The following is a description of a gene set: studied in species Homo sapiens Cell Cycle, Mitotic Human Gene Set: REACTOME_CELL_CYCLE_MITOTIC, and this is the list of marker genes: CEP192, H4C15, ORC4, CENPU, CENPL, H2AC8 (NCBI Gene Id 3012), TUBGCP4, ADRM1, PSMD8, POLD3, MCPH1, AAAS, CENPI, GORASP2, ORC2, TUBB2A, YWHAE, H3C1, CLASP1, H3C11, DNA2, NINL, CEP70, PSMB4, CDC7, MCM10, H2BC5, FIRRM, RFC5, CCNH (cyclin H), PTTG1, CENPF, NCAPH, CEP41, ABL1, CCNE2, LIN9, RBX1, FBXL7, PPP2CA, USO1, PSMA5, E2F6, RANGAP1, CDKN2A, CDT1, PPME1 (NCBI Gene Id 51400), BLZF1, FBXL18, GINS2, XPO1 (exportin 1), CNEP1R1, HDAC1, RPA4, CDC25A, NCAPG, POLD2, TUBGCP6, FBXW11, TUBA1A, CEP131, DYNC1LI1, NUMA1, PSMA1, PPP2R5B, PRKCA, LEMD3, TUBA1B, TOP2A, MIS18BP1 (MIS18 binding protein 1), H4C13, ZWILCH, LIN37, TUBA3C, NUP85, DCTN2, RRM2, OFD1, UBA52, H4C1, PLK4, UBE2I, CENPC, H4C5, GINS3, NME7, NUP43, FOXM1, H2BC6, RAE1, BTRC, CDKN2C, H3C10, NUP107, AKT1, E2F5, TFDP2, CEP290, H2BC15, UBC, ESPL1, ESCO2, MCM8, PKMYT1, ANAPC5, ANAPC7, CEP250, MZT2A, H2AC18, VPS4A, TUBG1, PDS5A, B9D2, MASTL, SKP1, CHMP6, BUB1B, CDK7, H4C14, H3C8, CDK11B, RAB8A, RCC1, H2BC3, SMC3 (NCBI Gene Id 9126), GTSE1, H3-3A (NCBI Gene Id 3020), SEC13, TUBA8, ERCC6L, PSMB3, CENPN, NSL1, MAPK3, SPAST, DBF4, PSMD6, ESCO1, H2BC7, MAD1L1, CCND2, HAUS1, KIF23, HSP90AA1, PSMC5, PPP2R1B, CEP135, HDAC8, CLIP1, CENPS, RFC2, CKAP5, MZT2B, RAD21, PSMB2, RBL1, FKBPL, H2BC11, PSMC6, PPP2R5C, NUP205, LYN, PMF1 (polyamine modulated factor 1), CEP152, POLA2, BIRC5, ZW10, GORASP1, PPP1CB, SKP2, CEP72, H2BC9, SMC1A, DSN1, SMC2, RCC2, FBXO5, SPC25, ENSA, LIN54, CENPP, BUB3, RPA1, CDC16, CENPM, CCND3, CSNK2B, CDC20, NUP37, KPNB1, LIG1, NDEL1, HJURP, OBI1, CABLES1, AKT3, PRIM1, RB1, RAN, H2AC7, H2AB1, PSMC1, CCNE1, SKA1, H2BC13, STAG1, CKS1B, NUP214, NDC80, CHMP3, GMNN, CHMP2B, LEMD2, NEK7, RPS27, NCAPH2, TUBB8B (tubulin beta 8B), H2AC20, CDC25B, KIF2A, UBE2S, TUBA4B, PSMD7, CSNK1E, NUP50, SUMO1, ANAPC1, MYBL2, AURKA, PPP2CB, ANAPC11, PTK6, CETN2, NEK2, H3C13, NUP58, DYNLL2, CDC14A (cell division cycle 14A), CDK2, PPP2R1A, TNPO1, TFDP1, AKT2, WEE1, CDKN1C, POLE3, PRKCB, CLASP2, RBBP4, NEK6, TUBB4B, PSMB7, CDKN1A, NUP133, PSMD14, TUBA3D, PPP2R2D, H2AC14, NEK9, PCNA, MCM3, MCM7, PRIM2 (DNA primase subunit 2), PPP2R5D, GINS4, RBL2, CEP63, PSMD1, POLD4, VRK1, STAG2, TUBGCP5, INCENP (inner centromere protein), MCM6, TUBB3, FEN1, HAUS4, SMC4, H2BC12L, TUBAL3 (tubulin alpha like 3), AJUBA, CDC25C, ARPP19, NIPBL, PPP2R5A, CDCA5, MCM5, CHMP4B, H2AJ, POLE4, E2F4, CENPJ, UBE2C, TPR, E2F3 (NCBI Gene Id 1871), CDC23, PPP1CC, ZWINT, SSNA1, MAX, H4C16, PPP1R12A (NCBI Gene Id 4659), TUBB2B, KIF20A, CNTRL, PPP1R12B, TK1, H3C6, MCM2, PSMA7, UBE2E1, NUP155, CENPQ, EMD, H2BC1, NEDD1, LMNA, CDC45, HAUS7, MIS12, E2F2, TUBA3E, RAB2A, UBE2D1, UBB, NUP54, H3C2, NUF2, OPTN, LPIN3 (NCBI Gene Id 64900), EP300, CDC27, TUBB1, ORC5, H2AX, H3C3, PRKAR2B, SET, PHF8, CC2D1B, NDC1, SGO1 (shugoshin 1), PCNT, CCNB2, BUB1, LBR, SGO2, H2BC17, PLK1, PHLDA1, H2AC4, TYMS (thymidylate synthetase), SPC24, TUBA1C, RPA2, RAB1B, PPP2R5E, FZR1, NUP62, ITGB3BP, PSMC4, PDS5B, PSMB6, TUBGCP3, H4C2, SEM1, SFI1, TUBG2, RAB1A, CHMP4C, NUP93, GOLGA2, PSMB5, ORC1, CENPT, SPDL1 (NCBI Gene Id 54908), CSNK2A2, AHCTF1, DYNLL1, HAUS2, H2BC12, HSP90AB1, H2AC19, HMMR, E2F1, SRC, PSMD2 (proteasome 26S subunit ubiquitin receptor, non-ATPase 2), PSMA3, H3-4, POLD1, NUP42, CDK4, VRK2, H2BC4, YWHAG, H4C8, MCM4, CDCA8, BORA, DYNC1I1, CCND1, H3C4, H2AZ2, KIF2C, MAPRE1 (microtubule associated protein RP/EB family member 1), TUBA4A, NUP188, NUP160, PSMD3, ANKLE2, SKA2, KNTC1, MYC, LCMT1, POM121, NUP88, CDKN1B, LPIN2, TUBB8, CUL1, CENPK, PSMA2, POLE2, NCAPD2, CDK5RAP2, ANAPC10, MAD2L1, ANAPC16, RFC4, CDK11A, H2BC14, WAPL, CDK1, CDC26, ANAPC15, PSMD11, CSNK1D, CEP76, ORC3, ANAPC2, TUBGCP2 (NCBI Gene Id 10844), MZT1, SEH1L, DCTN3, CENPO, RPS27A, DYRK1A (dual specificity tyrosine phosphorylation regulated kinase 1A), NUP210, H4C11, DYNC1LI2, POLE, CENPH, NUP98, GSK3B, PCM1, POLA1, HAUS5, CEP164, CCNA1, TUBB, KMT5A, H2BC10, KNL1, CEP43, LIN52, LMNB1, ALMS1, RANBP2, ORC6, CEP57, H3C12, DHFR, H2BC8, NDE1, RFC3, AURKB, CCNA2, CHMP2A, CHMP4A, PPP2R3B, NUP153, DYNC1I2, CTDNEP1, PAFAH1B1, HAUS6, GINS1, JAK2, H3C14, HAUS8, H2BC26, POM121C, TMPO, CDK6, CEP78, PSMD12, H3-3B, BANF1, PPP2R2A, IST1, RPA3, TICRR, DYNC1H1, H2AC6, CDKN2D, TUBB6, CDC6, PSMB1, NUP35 (NCBI Gene Id 129401), TP53 (NCBI Gene Id 7157), CHMP7, PSMA4 (proteasome 20S subunit alpha 4), NUDC, H3C15, AKAP9, CENPA, PSMA6, MAU2, PSMC3, ACTR1A, H4C3, KIF18A, CCNB1, LPIN1, MAPK1, H2BC21, KIF2B, ODF2, CENPE, H4C6, PSMD13, SIRT2, ANAPC4, HAUS3, CDKN2B, H3C7, EML4, DCTN1 (dynactin subunit 1), MNAT1, CCP110, TPX2, PSMC2, CSNK2A1, NCAPG2, SDCCAG8, H4C4, H4C12 (H4 clustered histone 12), TUBB4A, H4C9, TAOK1, RFC1, PRKACA, NCAPD3